The following is a description of a gene set: species: Homo sapiens A small, skin-lined tract that leads from the surface to deep within the tissues. Human Gene Set: HP_SKIN_PIT Skin pit, and this is the list of marker genes: IRF6, STAG2, PTCH2, AUTS2, KDR, ATP2A2, GNAI3, SIX1, POGLUT1, FGFR2, NECTIN1, B3GLCT, KRT5, SUFU, NELFA, WBP11, GATA5, GPC3, LRP1, CRELD1, LETM1, CIB1, POFUT1, EIF2AK3, FBXO11, GSC, GRHL3, KAT6A, TBX1, NKX2-6, MED12 (NCBI Gene Id 9968), FLNA, TFAP2A, OFD1, RAB23, FGFRL1, NSD2 (nuclear receptor binding SET domain protein 2), ZNF462, HNRNPK, PSENEN, RIPK4, DICER1, MSX1, GPC4, GATA6, JAG1, GATA4, H4C9, KDM6A, SMO, EYA1, CPLX1, GDF1, SALL1, PIGG, EDN1, PLCB4, KCNJ2, NKX2-5, ANK1, CITED2 (Cbp/p300 interacting transactivator with Glu/Asp rich carboxy-terminal domain 2), NPHP3, XYLT2, TRPM3 (NCBI Gene Id 80036), EDNRA, SIX5, ZFPM2, HK1, PAX1, PTCH1 (NCBI Gene Id 8015), PPP1CB, UBE2A, CTBP1, POLR1D, FLT4, MITF, TP63, SYK, GJA5, MID1, KMT2D, SPECC1L, RERE